The following is a description of a gene set: species: Mus musculus Mouse Gene Set: REACTOME_RAB_REGULATION_OF_TRAFFICKING Rab regulation of trafficking, and this is the list of marker genes: Tsc1, Trappc13, Rgp1, Mon1a, Ankrd27, Map1lc3b, Tbc1d7, Tbc1d10c, Tbc1d10b, Rabgap1, Dennd3, Rab27b, Trappc12, Trappc10, Dennd2a, Dennd2d, Rab33a, Rab14, Dennd4a, Madd, Rab5a, Rab33b (NCBI Gene Id 211346), Trappc3, Rab11a, Rab6a, Rab5b, Gabarapl2, Als2, Trappc6a, Rab1a, Rin1, Trappc1, Rab39, Trappc6b, Trappc2, Rabgef1, Gdi1, Tbc1d10a, Trappc5, Rab18, Dennd1b, Rab3gap1, Dennd4c, Rab27a, Sbf2, Optn, Dennd1a, Tbc1d24, Als2cl, Chml, Rin2, Rin3, Rab3il1, Rab6b, Rab7b (RAB7B, member RAS oncogene family), Rab7, Trappc8, Dennd6b, Trappc9, Rab10, Dennd2b, Tbc1d2, Akt3, Rab8a, Ccz1, Gdi2, Tbc1d15, Hps1, Rab11b, Rab9b, Tsc2, Ric1, Rab5c, Rab12, Rinl, Rab21, Chm, Tbc1d14, Hps4, Rab3gap2, Akt1, Rab13, Dennd2c, Sbf1, Dennd5b, Rab1b, Tbc1d17, Trappc2l, Rab39b, Akt2, Arf6, Gapvd1 (GTPase activating protein and VPS9 domains 1), Rab32, Dennd4b, Gabarap, Rab9, Dennd5a, Rab35, Rab31, Tbc1d16, Dennd1c, Trappc11, Mon1b, Ywhae, Sytl1, Rab4a, Dennd6a, Tbc1d13, Rab38, Rab3a, Tbc1d25, Rab8b, Ulk1, Rab3ip, Trappc4